The following is a description of a gene set: studied in species Mus musculus Mouse Gene Set: GOBP_CERAMIDE_METABOLIC_PROCESS The chemical reactions and pathways involving ceramides, any N-acylated sphingoid., and this is the list of marker genes: Sgpl1, St6galnac5, Neu3, Gm6993 (predicted gene 6993), Fa2h, Smpd4, St8sia4, Agk, Acer1, Sgms2, Alox12b, St3gal1, Smpd3, Pla2g15, B4galnt1, Abca12, Smpd1, Acer2, P2rx1, Lct, Aloxe3, Cyp4f39, Asah2, Cers4, Ormdl2, Gal3st1, B3galt4, Cers5, St8sia3, Casp1, Fut7, Cerk, Tlcd3b, Hexa, Smpd2, Abca2, Cert1, Sptlc1, Sgms1, St6galnac3, Neu2, Pnpla1, Neu1, St6galnac6, Ugcg, Cers6, Gsdmd, P2rx7, Gba2, Degs1, B4galt6 (UDP-Gal:betaGlcNAc beta 1,4-galactosyltransferase, polypeptide 6), 6430550D23Rik, Sphk2, St6galnac4, Casp7, Gm2a, B3galt2, St8sia2, Ormdl3, Samd8, Sirt3 (sirtuin 3), Enpp7, Prkcd, Degs2, Ugt8a, Cln8, Cel, Sptlc3, Sptssa, Ormdl1 (NCBI Gene Id 252836), Elovl1, Cers3 (NCBI Gene Id 74802), Paqr4, Psap, B4galt5, Sptlc2, Mecr, Gba1, Gla (galactosidase, alpha), Sptssb, Cers1, B3galt1, Acer3, Cers2, Plpp2, Glb1, Degs1l, Itgb8, Plpp3, St3gal3, Plpp1, Prf1, Ccn1, Asah1, Neu4, Zfp750, Htra2, B4galt4, Pla2g6, Hexb, B4galt3 (NCBI Gene Id 98672), Smpd5, Tm9sf2, Cln6 (ceroid-lipofuscinosis, neuronal 6), St8sia6, St3gal2, Naglu, Sphk1, Galc, Gzmb (NCBI Gene Id 14939), St6galnac1